The following is a description of a gene set: from publication Bennett L, Palucka AK, Arce E, Cantrell V, Borvak J, Banchereau J, Pascual V (PMID 12642603) Systemic lupus erythematosus (SLE) is a prototype systemic autoimmune disease characterized by flares of high morbidity. Using oligonucleotide microarrays, we now show that active SLE can be distinguished by a remarkably homogeneous gene expression pattern with overexpression of granulopoiesis-related and interferon (IFN)-induced genes. Using the most stringent statistical analysis (Bonferroni correction), genes were found highly up-regulated in SLE patients, 14 of which are targets of IFN and one, defensin DEFA-3, a major product of immature granulocytes. A more liberal correction (Benjamini and Hochberg correction) yielded 18 additional genes, 12 of which are IFN-regulated and 4 granulocyte-specific. Indeed immature neutrophils were identified in a large fraction of SLE patients white blood cells. High dose glucocorticoids, a standard treatment of disease flares, shuts down the interferon signature, further supporting the role of this cytokine in SLE. The expression of genes correlated with disease activity according to the SLEDAI. The most striking correlation (P < 0.001, r = 0.55) was found with the formyl peptide receptor-like 1 protein that mediates chemotactic activities of defensins. Therefore, while the IFN signature confirms the central role of this cytokine in SLE, microarray analysis of blood cells reveals that immature granulocytes may be involved in SLE pathogenesis. Genes significantly up-regulated in the blood mononuclear cells from patients with systemic lupus erythematosus compared to those from healthy persons. Human Gene Set: BENNETT_SYSTEMIC_LUPUS_ERYTHEMATOSUS studied in species Homo sapiens, and this is the list of marker genes: OAS1, LGALS3BP, ISG15, FPR2, IFI35, XAF1, CAMP, AGRN, TAP1, RNASE2, OAS2, MX2, LY6E, S100A8, MX1 (NCBI Gene Id 4599), CKAP4, TDRD7, OASL, SERPING1, DEFA3, PLSCR1, STAT1, IFITM3, IFI44L, IRF7, DEFA1, TNFSF10, IFIT3, APOBEC3B